The following is a description of a gene set: Human Gene Set: GOBP_CELL_CELL_ADHESION_MEDIATED_BY_CADHERIN studied in species Homo sapiens The attachment of one cell to another cell via a cadherin, transmembrane proteins having repeating extracellular calcium ion binding domains., and this is the list of marker genes: CD2AP (CD2 associated protein), WNT5A, CTNNB1, CDH18, SMAD7, AFDN, MAD2L2, WNT3A (NCBI Gene Id 89780), CDH17, PTPRU, CDH20, FER, EPCAM, SERPINF2, NOTCH4, CDH3, NEXMIF, CDH4, CDH9, RGCC, CDH24, FOXA1, CDH13, CDH15, CDH19, DENND6A, CDH1, TGFB1, ADAM19, PPM1F, CDH10, FLOT1, CDH2, CTNND1, PLEKHA7, CDH12, BMP6, CDH6, FOXA2, CDH11, TJP1, MMP24, CDH8, PLG, BHLHA15, CDH5, NOTCH1, VEGFA, CDH26, CDH7, CDHR2, CDHR3, CDH22